The following is a description of a gene set: Genes down-regulated in monocytes (6h): untreated versus muramyl dipeptide andM. tuberculosis 19 kDa lipopeptide. studied in species Homo sapiens from publication Schenk M, Krutzik SR, Sieling PA, Lee DJ, Teles RM, Ochoa MT, Komisopoulou E, Sarno EN, Rea TH, Graeber TG, Kim S, Cheng G, Modlin RL (PMID 22447076) Human Gene Set: GSE34156_UNTREATED_VS_6H_NOD2_AND_TLR1_TLR2_LIGAND_TREATED_MONOCYTE_DN human blood monocytes were isolated, activated and harvested at several timepoints In this study, we identified genes that were differentially expressed in human monocytes activated with eiter NOD2L and/or TLR2/1L., and this is the list of marker genes: PRUNE2, TAP1, IRF7, RSAD2, NR3C1, SIPA1L1, OGDH, DNMT3A, GLS, HERC5, P2RY14, PSEN1, PAPOLA, FNBP1L, MAN1B1, COPG2, TNFSF10, LRATD2, TRIM14, PARP12 (NCBI Gene Id 64761), TGS1, OAS3, IFIT1, AGAP2, SAMSN1, MOB1A, SAMHD1 (SAM and HD domain containing deoxynucleoside triphosphate triphosphohydrolase 1), ADGRL4, SF3B1, IFI44, MOV10, MFAP3, ARHGEF2, DIPK1A, ZEB1, SWAP70, CASP2, RIGI, SEPTIN2, DDX60, FCRL1, IFIT2, SAMD9L, OASL, PRPSAP2, MARCHF6, IKZF1, NSD3, PSMB9, PRSS16, MSS51, ITPR1, ITPK1, MFN2, EHD4, TRIM34, TRIM21 (tripartite motif containing 21), RNF213, CMTR1, GVINP1, XAF1, PHF8, RIPK4, KDM4C, FCGR1A, FGL2, TMEM229B, CWC22, NIBAN1, COMMD8, DHX36, ADGRG6, SH3PXD2A, CXCL10, GTPBP1, LRRC8C, DCUN1D1, IFIH1, MX2, GBP5, TDRD7, MED13L, RNF31, EWSR1, TMOD3, VPS33A, ITSN1, CDK19, NFXL1, UBE2L6, OAS2, CXCR3 (C-X-C motif chemokine receptor 3), SLC9B2, NOX1, TLE1, RSBN1, TLR3, NSF, GBP3, STAT2, LY6S, RASGRP4, ARHGAP30, NMI, MBTPS1, IRGM, RTP4, LEMD1, NXPE1, STAP1, SGPP1, LY6E, RND3, PYGB, IFI16, IFIT3, PARP11, LIFR, IREB2 (iron responsive element binding protein 2), PPIP5K2, BIRC2, INO80C, CRYBG1, DAZAP2, KIF3B, INTS8, SLFN5, HDAC3, TMEM106A, PIK3AP1, XKR5, TMEM87A, SP100, DEPDC5, TESMIN, ETNK1, CHEK2, TRIM5, NINL, ADAR, PLCB4, ABI1, STAT1, SMAGP, TLR1, CD72, ATP11B, BLNK, JARID2, PPP1R9B, ITGA4, USP18, NABP1, EIF2AK2, ZBP1, MX1, CTCF, SMAD1, RAPGEF2, CTR9